Given this list of marker genes Cnn2, Dysf, Syt11, Adipoq, Atg5, Plscr1, Cd47, Appl1, Tgfb1, Pip4p2, Atg3, Pten, Sirpa, Sftpd, Prtn3, Snx3, Tlr2, Fcgr2b, Siglece, Cd300lf, Atg7, Csk, Hmgb1, Rack1, Cd300a, here is a description of the gene set: Mouse Gene Set: GOBP_NEGATIVE_REGULATION_OF_PHAGOCYTOSIS Any process that stops, prevents, or reduces the frequency, rate or extent of phagocytosis. species: Mus musculus